Given this list of marker genes Gm3351, Gm8599, Otol1, Sptssb, Gm23484 (predicted gene, 23484), Gm6631, Gm17895, Gm19194, Gm23477, Gm8604, here is a description of the gene set: studied in species Mus musculus Mouse Gene Set: chr3E2